Given this list of marker genes KLK10, ANKRD36C, MALL, CST6, MT1X, CEACAM5, ALDH1A3, TNFRSF12A, C15orf48, RAB11FIP1, KLF2, CEACAM1, KRT23, ANXA1, EMP1, IL1RN, SLPI, CEACAM6, KLK11, PLAUR, SLC2A1, MUC5AC, KRT16, EPS8L1, SMIM5 (NCBI Gene Id 651168), LMO7, LCN2, COL6A1 (collagen type VI alpha 1 chain), SDCBP2, ISG15, ISG20, PSCA, LAMC2, LRRC8A, TFF2, CD55, CLDN23, IL32, KLK6, S100A4, FLNB, APOL1, LDLR, SLC16A3, KRT17, CLIC3, TIMP2, F3, KLK7, MMP7, here is a description of the gene set: species: Homo sapiens from publication Gavish A, Tyler M, Greenwald AC, Hoefflin R, Simkin D, Tschernichovsky R, Galili Darnell N, Somech E, Barbolin C, Antman T, Kovarsky D, Barrett T, Gonzalez Castro LN, Halder D, Chanoch-Myers R, Laffy J, Mints M, Wider A, Tal R, Spitzer A, Hara T, Raitses-Gurevich M, Stossel C, Golan T, Tirosh A, Suvà ML, Puram SV, Tirosh I (PMID 37258682) Human Gene Set: GAVISH_3CA_MALIGNANT_METAPROGRAM_40_PDAC_RELATED In this study, an extensive analysis was conducted to define meta-programs (MPs) capturing intra-tumor heterogeneity across a spectrum of tumor types. The approach utilized non-negative matrix factorization (NMF) to analyze each cell type separately within individual tumor samples. This involved the analysis of malignant cells, macrophages, fibroblasts, endothelial cells, epithelial cells, T-cells, and B-cells. NMF was executed with varying parameter values (K=4, 5, 6, 7, 8, 9), thereby generating 39 programs for each cell type per sample. Each NMF program was summarized by the top genes based on NMF coefficients.\nRobust MPs were then delineated for each cell type using a set of stringent criteria, including recurrence within the same tumor, similarity to programs in other tumors, and non-redundancy within a tumor. Subsequently, these robust NMF programs were clustered (per cell type) based on Jaccard similarity, leading to the identification of MPs associated with each cell type.\nTo enhance the quality of the MPs, a refinement steps were undertaken, involving the removal of MPs suspected of reflecting low-quality data (with an overrepresentation of ribosomal proteins or mitochondrial-encoded genes), single-study inclusion, or similarity to miss-annotated cell types. Genes upregulated in subsets of cells of a given type within various tumors